The following is a description of a gene set: studied in species Mus musculus The directed movement of carbon dioxide (CO2) into, out of or within a cell, or between cells, by means of some agent such as a transporter or pore. Mouse Gene Set: GOBP_CARBON_DIOXIDE_TRANSPORT, and this is the list of marker genes: Car2, Aqp1, Hba-x, Hbb-bs, Car14, Aqp5, Car12, Hbb-bh1, Hbb-y, Rhcg, Aqp6, Car4, Rhag, Hba-a1, Aqp4, Rhbg